Given this list of marker genes CCDC88A, GTF2E2, RPL5, BANF1, SMAD4, LZTFL1, TGFB2, MPLKIP, EBP, RPL10, MAMLD1, CDC6 (NCBI Gene Id 990), SLC25A24, DYRK1A, FOXP1, TRIP11, TASP1, RPS19, IFT74 (intraflagellar transport 74), TCTN3, FZD2, IGF2, HEY2, RBBP8, CTNND2, SPEN, NDE1, EIF4A3, NEDD4L, MAGEL2, FRMPD4, RTL1, MYL11, OTUD5, HSD17B4, C1GALT1C1, NAA80, MIA3, WDR35, MADD, POLR1D, NDUFB11, NARS1, SCAPER, THSD4, IFT172, TNPO2, EDEM3, KMT2D, ORC1, CCBE1, NSMCE2, KCNK9, BBS9, AMER1, COG6, DBR1, CEP295, HPDL (4-hydroxyphenylpyruvate dioxygenase like), DGCR6, COL2A1, TTN, ATP6V0A2, DSTYK, ASXL1, GLE1, CEP55, SMOC1, BBS1, CTCF, AGRN, PMM2, SLC18A3, ARCN1, MYO9A, CNTNAP1, CTBP1, GABRA3, HYMAI, DGCR2, HBA2, MFAP5, SEC61A1, ATP6V1A, MYCN, IFT27, RNU4ATAC, C2CD3, USB1, H4C5, SLC10A7, ZNF699, CENPJ, ODC1, MYMK, BLM, TGFB3, SRCAP, ERCC2, CFAP418, ASXL3, ELN, TUBA1A, EED, MYH11, WNK3, PRMT7, DIS3L2, TAF1, OFD1, ARL6 (NCBI Gene Id 84100), FBN1, TBX1, GTF2H5, PREPL, TMEM70 (transmembrane protein 70), TAF4, FOXF1, SUZ12, ALG11 (NCBI Gene Id 440138), FRA10AC1, CHST3, DPYD, SIM1, ARNT2, FANCB, FAM20C, DVL3, COX7B, PIGN, GBA1, PPP3CA, PRDM13, BBS10, GLDN, SLC5A7, BBS5, SCNM1, BCL11A, MOGS, ORC6 (origin recognition complex subunit 6), TGFBR1, IGBP1, SCN4A, DSE, NPHP1, NUDT2, NUP188, TMEM107, SLC25A1, NSD1, COL3A1, SIN3A, KATNB1, BBS2 (Bardet-Biedl syndrome 2), ITGA8, CEP135, INTS11, SMAD2, EXOSC5 (NCBI Gene Id 56915), PUF60, RNF113A, RELN, EFEMP2, SELENON, MEG3, SIX5, GAD1, RSRC1, CA2, RAP1GDS1, SLC3A1, SEMA5A, FARS2, FHL1, TPM2, HNRNPH1, DHCR7, AUTS2, CANT1, PIEZO2, FOXE3, OCLN, HNRNPK, ZNHIT3, EP300, CEP290, RTTN, SMC3, TELO2, KAT6B, ADAMTS2, LMNA, MEGF8, FDFT1, EDN1, MKS1, FUT8, POLR1C, BNC2, RYR1, SYT2, KIF7, ROR2, ZMPSTE24, AARS1, NUP88, DGCR8, FAT4, SMC1A, MKKS, ADAMTSL2, CREBBP, DHCR24, COL1A2, YARS1, KIF15 (NCBI Gene Id 56992), NFIX, AP3D1, TGFBR2, CBL, ERCC3, TXNDC15, ALG9, MRPS22, CEP120, PAX1, CDT1, GLI3, VAMP1, POLR1B, TRIP4, CDC45, TARS1, BBS4, TTC8, FBXL3, SDCCAG8, NBN, PSMD12, BMP4, B3GAT3, WNT5A, NAA10, SF3B4, MSL3, ACTA2, KMT2B, TRIO, RNU4-2, KAT6A, BRCC3, FBXW11, MGAT2, PRORP, MED25, KIF26A, ALG13, IBA57, HECTD4, PRKG1, EMC1, ABAT, ORC4, WDR11, MYLK, SNRPN, SETBP1, FOXE1, HCCS, JARID2, OTUD6B, DHX9, DLK1, CRPPA, KPTN, CHD8, RARB, SEC24D, SKI, ASPH, BIN1, DVL1, UBE3B, TCOF1, SNAP25, EXOSC1, SIX1, POGZ, ASXL2, BBS7, LTBP4, GMNN (NCBI Gene Id 51053), ESAM, INTU, LBR (NCBI Gene Id 653311), IDH1, LGI4 (leucine rich repeat LGI family member 4), EZH2, ARID1B, MAPKAPK5, TRIM32, MYH7, CEP152, UBA2, PRR12, ATG7, ERF, SCO2, SCLT1, ZC4H2 (zinc finger C4H2-type containing), RAP1B, CRLF1, MESD (mesoderm development LRP chaperone), DDB1, CEP19, SPEG, CASK, WBP11, PIK3C2A, ATPAF2, LOX, HYLS1, EYA1, THOC6 (THO complex subunit 6), ACTG1, SLC4A10, CHST14, BBIP1, HS2ST1, NEPRO, MAT2A, CREB3L1, HDAC8, CTU2, H4C3, RSPO2, EXOC7, CSGALNACT1, U2AF2, POLR3A, WBP4, COG5, COG7, RAB34, POLR1A, IPO8, PUS7, ZFX, NR2F1, PCNT, FTO, BBS12, ARID2, POLA1, AFG2A, CARS1, COL1A1, FBXO31, PDGFRB, NSDHL, HBA1, SLC29A3, KDM6A, ACTA1, ACTB, MTM1, FBXO11, PLAGL1, ESS2, SMAD3, CHAT, ADAMTS3, SLC35A3 (solute carrier family 35 member A3), SLC35B2, COL13A1, MBD5, SLC6A9, CRIPT, INTS1, ZBTB24, WDPCP, IGF1R, SETD2, here is a description of the gene set: Retrognathia Human Gene Set: HP_RETROGNATHIA studied in species Homo sapiens An abnormality in which the mandible is mislocalised posteriorly.